The following is a description of a gene set: electronically inferred by orthology from the curated human pathway species: Mus musculus part of: PIP3 activates AKT signaling This event has been computationally inferred from an event that has been demonstrated in another species.<p>The inference is based on the homology mapping from PANTHER. Briefly, reactions for which all involved PhysicalEntities (in input, output and catalyst) have a mapped orthologue/paralogue (for complexes at least 75% of components must have a mapping) are inferred to the other species. Reactome Pathway: AKT phosphorylates targets in the nucleus, and this is the list of marker genes: Rps6kb2, Foxo6, Nr4a1, Foxo4